Given this list of marker genes CCL4L2 (C-C motif chemokine ligand 4 like 2), DUSP2, EREG, SAMSN1, PLAUR, CXCL2, NAMPT, LYZ, PLIN2, C15orf48, IER3, HBEGF, NLRP3 (NCBI Gene Id 9558), CD83, AREG, PPP1R15A, SLC25A37, NR4A2, IL1RN, IL1B, S100A9, PTGS2, FOSB, CD55, FCN1, S100A8 (NCBI Gene Id 6279), GPR183, G0S2, CCL4, THBS1, CCL3L3, NFKBIZ, TNFAIP3, TREM1 (triggering receptor expressed on myeloid cells 1), AQP9, RGS2, CCL3, SOD2, TIMP1, SLC2A3, SOCS3, CCL20, CXCL3, CXCL8, BCL2A1, ATF3, SLC11A1, NFKBIA, OLR1, VCAN, here is a description of the gene set: from publication Gavish A, Tyler M, Greenwald AC, Hoefflin R, Simkin D, Tschernichovsky R, Galili Darnell N, Somech E, Barbolin C, Antman T, Kovarsky D, Barrett T, Gonzalez Castro LN, Halder D, Chanoch-Myers R, Laffy J, Mints M, Wider A, Tal R, Spitzer A, Hara T, Raitses-Gurevich M, Stossel C, Golan T, Tirosh A, Suvà ML, Puram SV, Tirosh I (PMID 37258682) In this study, an extensive analysis was conducted to define meta-programs (MPs) capturing intra-tumor heterogeneity across a spectrum of tumor types. The approach utilized non-negative matrix factorization (NMF) to analyze each cell type separately within individual tumor samples. This involved the analysis of malignant cells, macrophages, fibroblasts, endothelial cells, epithelial cells, T-cells, and B-cells. NMF was executed with varying parameter values (K=4, 5, 6, 7, 8, 9), thereby generating 39 programs for each cell type per sample. Each NMF program was summarized by the top genes based on NMF coefficients.\nRobust MPs were then delineated for each cell type using a set of stringent criteria, including recurrence within the same tumor, similarity to programs in other tumors, and non-redundancy within a tumor. Subsequently, these robust NMF programs were clustered (per cell type) based on Jaccard similarity, leading to the identification of MPs associated with each cell type.\nTo enhance the quality of the MPs, a refinement steps were undertaken, involving the removal of MPs suspected of reflecting low-quality data (with an overrepresentation of ribosomal proteins or mitochondrial-encoded genes), single-study inclusion, or similarity to miss-annotated cell types. species: Homo sapiens Genes upregulated in subsets of cells of a given type within various tumors Human Gene Set: GAVISH_3CA_METAPROGRAM_MACROPHAGES_MONOCYTE_SECRETED